Given this list of marker genes NUBPL, CDK6, H6PD, NT5C2, NUP85, LZIC, RPS6KA6, GPSM2, DCTPP1, KHSRP, MRPS2, WDR12, CENPN, NUDCD2, NUDC, UBQLN4, CDK4, STRAP, CNOT11, HPRT1, NUP107, GPX8, PRDX3, CRMP1, XPO7, MTHFD1L, ARL8B, NFIL3, NSL1, HSPH1, PSME3, MARS1, NAA50, MRPL35, PRICKLE3, MEMO1, SYPL1, DPY30, GATAD1, TADA2A (NCBI Gene Id 96291), TDP2, UAP1, DIP2A, GPR137B, ASF1A, HEATR5A, BOLA3, XBP1, MAN1C1, LAMC1, G3BP1, RBBP7, SECISBP2, PLK1, MIEF2, DTL, SPCS3, ATP6V1C1, TIAM1, COL6A3, IPO9, WRNIP1, PPP1R7, CDK12, TEDC1, SERPINE2, ADAT2, ZBED4, DYNC1LI2, NUP155, OXSR1, SEC23IP, NUDT5, STOML2, ANXA1, ORC1, SUV39H1, FOXK1, SF3A3, PAICS, CLDN12, MDN1, HNRNPH3, MCM10, NQO2, MMGT1, ACER3, DIS3, VPS50, TXN2, PTRHD1, PPIF, TP53BP2, TMEM41B, C1orf52 (chromosome 1 open reading frame 52), RANBP1 (RAN binding protein 1), NAE1, PATZ1, TARDBP, GCAT, PPA1, MKRN2, PLPP5, MTSS1, PCMT1, CEP170, MED7, MRPS24, HACD2, RCL1, PARD6B, BEX1, COPS5, SEPTIN10, BAG2, ALDH9A1, RRP15, PSMG2, FIGNL1, NASP, FAM234B, SLC30A5, IFNG, CDR2, ALG9, PRIM1, PATL1, AARSD1, ERN1 (NCBI Gene Id 63433), CCDC127, CHTF18, PCYOX1, NAMPT, PRELID3B, PRSS56, IWS1, ARMC5 (armadillo repeat containing 5), OGFOD3, GATAD2A, BTG3 (NCBI Gene Id 10950), CCND3, COQ7, SUZ12, MAPK6, WDR4, OSTC, PRDX4, PIGM, AGPAT5, ERLIN1, PRMT7, UBE3C, NDFIP1, GNL3, SLC19A2, CENPO, DDX31 (NCBI Gene Id 64794), PSMC2, RYK, GPR25, GPD2, FANCA, PPP2R1B, STX12, PBK, FBXO45, CA12, DOHH, ZNF639, VKORC1L1, STOM, PDCD11, NR2C1, AHCY, STK39, E2F6, PFKL, ARL4A, DNMT3B, UTP6 (UTP6 small subunit processome component), NARS1, LIG3, LRBA, DNAJC6, OSM, UTP18 (UTP18 small subunit processome component), NDUFAF5, IL1R2 (NCBI Gene Id 7850), GTF2H2, RAD51AP1, CYP2S1, RRP12, CLPX, ATP23, MRPL11, YBX3, RPP40 (ribonuclease P/MRP subunit p40), CMTM7, NUP62, SEC61A2, here is a description of the gene set: species: Homo sapiens from publication Kalia V, Sarkar S, Subramaniam S, Haining WN, Smith KA, Ahmed R (PMID 20096608) Genes down-regulated in comparison of effector CD8 IL2RA low T cells versus effector CD8 IL2RA high cells. Human Gene Set: GSE19825_IL2RALOW_VS_IL2RAHIGH_DAY3_EFF_CD8_TCELL_DN CD25, the high affinity interleukin-2 (IL-2) receptor alpha-chain, is rapidly upregulated by antigen-specific CD8+ T cells after T cell receptor stimulation. We demonstrated that during an acute viral infection, CD25 expression was dynamic, and a subset of virus-specific CD8+ T cells sustained CD25 expression longer than the rest. Examination of the in vivo fate of effector CD8+ T cells exhibiting differential responsiveness to IL-2 revealed that CD25lo cells, which were relatively less sensitive to IL-2, preferentially upregulated CD127 and CD62L and gave rise to the functional long-lived memory pool. In contrast, CD25hi cells that accumulate enhanced IL-2 signals, proliferated more rapidly, were prone to apoptosis, exhibited a more pronounced effector phenotype, and appeared to be terminally differentiated. Sustained IL-2 receptor signaling resulted in increased CD8+ T cell proliferation, higher granzyme B expression and exaggerated contraction after antigen clearance. These data support the hypothesis that prolonged IL-2 signals during priming promote terminal effector differentiation of CD8+ T cells.